The following is a description of a gene set: Mouse Gene Set: GOBP_CYTOKINE_PRECURSOR_PROCESSING The cleavage of a peptide bond in a precursor form of a cytokine, resulting in the mature (active) form of the cytokine. studied in species Mus musculus, and this is the list of marker genes: Gm15441, Pcsk5, Furin, Cma1 (NCBI Gene Id 17228), Casp1